Given this list of marker genes Tor1aip1, B2m, Tap2, Ifit1bl1, Il12rb1, Setdb2, Grn, Etnk1, Slc25a28, Tbrg1, Tgtp2, Ly6a, Ifitm3, Rnf139, Slfn1, Slamf7, Znfx1, Akr1b1, Nlrc5, Mndal, Ifi208, Cmpk2, Chmp4b, Irf9, Tmem184b, Trim25, Rasa4, Phyh, Hmgn3, Msn, Idnk, Marchf5, Evi2a, Stat1, Tspo, Tcstv4, Ifi35, Socs1, Cxcl10, Icam1, Naa20, Atp8a1, Ifit1, Cnot6l, Herc6, Cd2, Ifit3, Phc2, H2-T23 (NCBI Gene Id 15040), Zup1, Parp11, Acadl, Psme1, Ascc3, Phf11c, Ifi209, Trim30c, Dtx3l, H2-Q7, Shisa5, Ifih1, Crbn, Eif5a, Ifi214, 9930111J21Rik2, Triobp, Parp10, Il2rg, Csrp1, Nampt (NCBI Gene Id 68683), Herc3, Fnbp4, Slfn9, Eif2ak2, Tmem140, Nmi, Ifi206, Hk1, Ubald2, Mrpl30, Ccnd2, Rbck1, Unc93b1 (unc-93 homolog B1, TLR signaling regulator), Capza2, Hmox2, Lgals9, Epsti1, Mgat1, Morc3 (NCBI Gene Id 93946), Ms4a4c, Arf4, Txn1, Gbp9, Treml2, Parp14, Lamp2, H2-D1, Sppl2a, Rnf114, Gbp8, H2-K1, Oasl1, Psmb9, Ccrl2, Ube2l6, Cited4, Trim12c, Svbp, Atp8b4, Gzma, Usp18 (ubiquitin specific peptidase 18), Plscr3, Adar, Gbp4, Atg13 (autophagy related 13), Nt5c3, Phf11b (NCBI Gene Id 236451), Gbp7, Smchd1, Dhx58, Daxx, Senp1, Phf11a, Phf11d, Mx1, Psme2, Arl6ip1, Ap1s3, Ogfrl1, Oasl2, Cycs, Tmem106a, Trim26, St6galnac4, Fxr1, Trim12a, Rnf213, Dcp2, Calhm6, Tbc1d1, Tor1aip2, Ifi27l2a, Ubb, Tapbpl, Tasor2, Trafd1, Ifit3b, Selenow, Tapbp, Slfn8, B4galt5, Tap1, Mycbp2, Casp1, Irf8, Cpne3, Gbp3, Rbm3, Clec2d, Oas2, Lysmd2, Ncoa7, Taldo1, Ctss, Tmsb10, Mrgbp, Rbm43, Lgals3bp, Slfn5 (schlafen 5), Xaf1, Itpr1, Bst2, Prrc2c, Ilrun, Ifi44 (interferon-induced protein 44), H2-T22, Rnf14, Zcchc2, Rigi, Hspa8, Oas3, Aida, Hsp90ab1, Cxcl9, Rabepk, Ddx24, Ms4a4b, Psmb8, Snx2, Pttg1, BC051226, Gbp2, Smox, Samd9l, Scfd1, Wdr43, Rsad2, Tent4a, Oas1a, Tcof1, Myd88, Luzp1, Fam111a, Gbp5, Tut4, Laptm4a, Jaml, Aldoa, Ifit2, Igtp, Sdf2l1, Samhd1, Uba7, Pdia3, Pgd, Srsf3, Wars1, Gadd45g, Phip, Card11, Vars1 (valyl-tRNA synthetase 1), Gbp6, Hsh2d, Atp10a, Ifi203, Casp8, Cd47, Sp110, Gng12, Cd274, Dnaja1, Ms4a6d, Helz2, Ifi47, Mvb12a (multivesicular body subunit 12A), Phgdh, Keap1, Rab5c, Trim30a, Cd69, Reep3, Pomp, Jak2, Stat2 (NCBI Gene Id 80602), Slco3a1, Psma5, Clic4, Pml, Sp140, Dpp4, Dbnl, Sub1, Plac8, Camk2d, Ifi213, Ogfr, Psmb10, Parp12, Tmbim6 (NCBI Gene Id 68309), Irgm2, Pnpt1, Ddx60, Zc3hav1, Mov10, Tnfsf10, Mafk, Pecam1, Slfn2, Cd86, Tor3a, Arhgap26, Irf7, Ly6e, Max, Cysltr2, Isg20, Casp4, Cacybp, Stk39, Sp100, Zbp1, Pcgf5, Psme2b, Itm2b, Rbl1, Ptma, Trim30d, Trim14, Iigp1, Phlpp1, Gtpbp2, Insl6, Irgm1, Ppa1, Ifi204, Trim34a, Rtp4, Cnp, Plaat3, Med1, Igkc, Trim21, Baiap3, Psma2, Grina, Mitd1, Hspa5, Parp9, Isg15, Trim56, Usp25, Bbx, Rab19, AI837181, Tgtp1, Ms4a6b, Asb13 (NCBI Gene Id 97892), Apobec3, Irf1, here is a description of the gene set: Mouse Gene Set: CUI_T_CELL_GD_IFNB_RESPONSE_UP Cytokines mediate cell-cell communication in the immune system and represent important therapeutic targets. A myriad of studies have highlighted their central role in immune function, yet we lack a global view of the cellular responses of each immune cell type to each cytokine. To address this gap, the authors created the Immune Dictionary, a compendium of single-cell transcriptomic profiles of more than 17 immune cell types in response to each of 86 cytokines (>1,400 cytokine-cell type combinations) in mouse lymph nodes in vivo. A cytokine-centric view of the dictionary revealed that most cytokines induce highly cell-type-specific responses. For example, the inflammatory cytokine interleukin-1β induces distinct gene programmes in almost every cell type. A cell-type-centric view of the dictionary identified more than 66 cytokine-driven cellular polarization states across immune cell types, including previously uncharacterized states such as an interleukin-18-induced polyfunctional natural killer cell state. from publication Cui A, Huang T, Li S, Ma A, Pérez JL, Sander C, Keskin DB, Wu CJ, Fraenkel E, Hacohen N (PMID 38057668) species: Mus musculus Genes positively differentially expressed in cell type: γδ T cell upon treatment with cytokine: IFN-β in mouse lymph nodes in vivo.